Given this list of marker genes HPS3, RAB29 (NCBI Gene Id 8934), BBS5, HPS6 (HPS6 biogenesis of lysosomal organelles complex 2 subunit 3), GPR143, DCTN1, BLOC1S2, RAB17, HPS5, MLPH, AP1S3, HPS1 (HPS1 biogenesis of lysosomal organelles complex 3 subunit 1), AP3M1, CDH3, BLOC1S4, AP1B1, BLOC1S3, TYRP1, RAB1A, AP1S1, RAB27A (RAB27A, member RAS oncogene family), HPS4 (NCBI Gene Id 89781), BBS7, RAB11A, DTNBP1, AP3D1, PMEL, CD63, VPS33A, AP1G1, ZEB2 (zinc finger E-box binding homeobox 2), BLOC1S5, AP1S2, SHROOM3, MAP2K1 (mitogen-activated protein kinase kinase 1), ASIP, BLOC1S6, AP3S2, SHROOM2, LYST, KIF13A, MKKS, MYO5A, BCL2, RAB11B, MYO7A, DCTN2, AP3B1, BACE2, AP3S1, ANKRD27, BLOC1S1, SNAPIN, AP1M1, BBS2, ABCB6, POMC, ARL6, PIKFYVE, APOE, VPS33B, RAB32, MREG, RAB38, here is a description of the gene set: species: Homo sapiens Human Gene Set: GOBP_CELLULAR_PIGMENTATION The deposition or aggregation of coloring matter in a cell.